Given this list of marker genes CTNND1, HLA-DQA1, FUT4, CEPT1, TAF1C, HSD17B10, CCN2, ZNF507, TXNRD2, TAF10, ITGB8, TP53I11, GALNT2 (NCBI Gene Id 2590), GNPNAT1, PRDX4, LCK, NCOR1, SGCB, ATP5ME, SGPL1, HNRNPC, SLC30A5, RHOB, UGCG, USP1, ARPC1B, CNKSR1, FLOT1, COL17A1 (NCBI Gene Id 7828), HGF, SYK, SOX7, NDRG1, SOX9, PDE3A, PDCD5, CTCF, here is a description of the gene set: The accumulation of DNA damage and mutations is considered a major cause of cancer and aging. While it is known that DNA damage can affect changes in gene expression, transcriptional regulation after DNA damage is poorly understood. We characterized the expression of genes in human primary fibroblasts after exposure to three different kinds of cellular stress that introduces DNA damage: 4-nitroquinoline-1-oxide (4NQO), gamma-irradiation, or UV-irradiation. Each type of stress elicited damage specific gene expression changes of up to 10-fold. A total of genes had similar changes in expression of 3-40-fold after all three kinds of stress. We examined transcription in cells from young and old individuals and from patients with Werner syndrome (WS), a segmental progeroid condition with a high incidence of cancer, and found various age-associated transcriptional changes depending upon the type of cellular stress. Compared to young individuals, both WS and old individuals had similarly aberrant transcriptional responses to gamma- and UV-irradiation, suggesting a role for Werner protein in stress-induced gene expression. Our results suggest that aberrant DNA damage-induced gene regulation may contribute to the aging process and the premature aging in WS. from publication Kyng KJ, May A, Stevnsner T, Becker KG, Kølvrå S, Bohr VA (PMID 15897889) Human Gene Set: KYNG_ENVIRONMENTAL_STRESS_RESPONSE_NOT_BY_4NQO_IN_WS species: Homo sapiens Human environmental stress response genes not changed in primary fibroblasts from Wilmor syndrom (WS) patients in response to 4NQO treatment.